Given this list of marker genes SNAI1, NEK6, ATF7IP, AVPR2, GAS5, here is a description of the gene set: from publication Bafna S, Singh AP, Moniaux N, Eudy JD, Meza JL, Batra SK (PMID 19010895) Numerous studies have established the association of MUC4 with the progression of cancer and metastasis. An aberrant expression of MUC4 is reported in precancerous lesions, indicating its early involvement in the disease process; however, its precise role in cellular transformation has not been explored. MUC4 contains many unique domains and is proposed to affect cell signaling pathways and behavior of the tumor cells. In the present study, to decipher the oncogenic potential of MUC4, we stably expressed the MUC4 mucin in NIH3T3 mouse fibroblast cells. Stable ectopic expression of MUC4 resulted in increased growth, colony formation, and motility of NIH3T3 cells in vitro and tumor formation in nude mice when cells were injected s.c. Microarray analysis showed increased expression of several growth-associated and mitochondrial energy production-associated genes in MUC4-expressing NIH3T3 cells. In addition, expression of MUC4 in NIH3T3 cells resulted in enhanced levels of oncoprotein ErbB2 and its phosphorylated form (pY(1248)-ErbB2). In conclusion, our studies provide the first evidence that MUC4 alone induces cellular transformation and indicates a novel role of MUC4 in cancer biology. species: Mus musculus Human Gene Set: BAFNA_MUC4_TARGETS_UP Genes up-regulated in NIH3T3 cells (fibroblast) engineered to stably express MUC4.